The following is a description of a gene set: A signaling process that controls cell cycle progression in response to changes in DNA structure by monitoring the integrity of the DNA. The DNA integrity checkpoint begins with detection of DNA damage, defects in DNA structure or DNA replication, and progresses through signal transduction and ends with cell cycle effector processes. studied in species Mus musculus Mouse Gene Set: GOBP_DNA_INTEGRITY_CHECKPOINT_SIGNALING, and this is the list of marker genes: Cdc5lrt1, Cdc6, Atf2, Brcc3, Dgkz, Mrnip, Mbd4, Cep63, Atr, Donson, Stk33, Trp53, Hus1 (NCBI Gene Id 15574), Mre11a, Chek2, Atm, Topbp1, Ppp1r10, Abraxas1 (NCBI Gene Id 71440), Nek1, Cry1, Msh2, Map3k20, Syf2, Brcc3dc, Rad9a, Foxn3, Dtx3l (NCBI Gene Id 209200), Lyn, Prpf19, E2f1, Creb3l1, Gigyf2, Clock (clock circadian regulator), Brca1, Eme1, Taok1, Mbtps2, Fbxo4, Cdc5lrt10, Babam1, Rps27l, Dna2, Plk1, Dot1l (DOT1 like histone lysine methyltransferase), Trex1, Cdk1, Rnaseh2b, Ccar2, Rhno1, Cdc14b, Cdk5rap3, Rad17, Mbtps1, Rfwd3, Cdc5lrt5, Tti1, Hinfp, Cdkn1a, Parp9, Rad51, Mapk14, Ufl1, Fancd2, Blm, Fem1b, Uimc1, Ercc6, H2ax, Cdc5lrt6, Dtl, Ints7, Etaa1, Sde2, Tiprl, Chek1, Rad9b, Eme2, Mus81, Zfp830, Nae1, Rint1, Clspn, Taok3, Babam2 (BRISC and BRCA1 A complex member 2), Ptpn11, Cdc5l, Trp53bp1 (NCBI Gene Id 27223), Mdc1, Cdt1, Cdc5lrt4, Nek11, Eif2ak4, Brd4, Cul4a, Nop53, Foxo4, Cdc5lrt9, Trim39, Nbn, Brsk1, Stk38, Ccng1, Cdc5lrt7, Cdc5lrt8, Xpc, Taok2 (TAO kinase 2), Brca2, Wac, Rad1, Fzr1, Gnb1l, Ticrr, D7Ertd443e, Wdr76, Tipin, Setmar, Ccnd1, Ier3, Fbxo31, Rpa2, Ptprv, Timeless, Usp28, Prkdc, Atrip, Hus1b, Bard1, Orc1